The following is a description of a gene set: Human Gene Set: WP_OMEGA3_OMEGA6_FATTY_ACID_SYNTHESIS studied in species Homo sapiens Omega-3 / omega-6 fatty acid synthesis, and this is the list of marker genes: PLA2G4A, PLA2G4B, ELOVL5, ACSL1, ELOVL2, ACOT1, ACSL4, PLA2G5 (NCBI Gene Id 5322), ACSL3, ACOT2 (acyl-CoA thioesterase 2), FADS1, FADS2, ACOX1, ACOX3, PLA2G6